Given this list of marker genes INS, HYMAI, BLK, PLAGL1, CEL, ZFP57, HNF1A, ABCC8, KLF11, HNF4A, KCNJ11, NEUROD1, PAX4, APPL1, PDX1, GCK, here is a description of the gene set: Human Gene Set: HP_TRANSIENT_NEONATAL_DIABETES_MELLITUS Transient neonatal diabetes mellitus studied in species Homo sapiens